Given this list of marker genes NIPA1, LRRC8E, MMGT1, ANKH, NIPAL4, AZGP1, NIPAL3, LRRC8A, LRRC8C, ADD3, MRS2, CTNS, DMTN, LRRC8B, ADD2, NIPAL2, NIPAL1, PIP, ADD1, CSN3, LRRC8D, TUSC3, SLC66A1 (solute carrier family 66 member 1), CSN1S1, NIPA2, MAGT1, here is a description of the gene set: Miscellaneous transport and binding events Human Gene Set: REACTOME_MISCELLANEOUS_TRANSPORT_AND_BINDING_EVENTS species: Homo sapiens